Given this list of marker genes WDR20, PPP2R2D, WWP2, PIGB, TRIM24, SSBP2, PSMC4, IKZF3, MAP7, PAG1, ALG13, KHDRBS1, ZNF207, SPPL2A, FOXN3, TRGV3, SLC40A1, IREB2 (iron responsive element binding protein 2), TRIM33, TSPYL1, CLPX, PPT1, NUDT9, RBBP4, GPR160, CA2, CXCR6, SRP54, HNRNPF, RIPK2, ABLIM1, SWAP70, TSNAX, DPYD, RIN2, HSPH1, CD96, LIPA, CCDC50, PRDM8, ZNF23 (zinc finger protein 23, NCBI Gene Id 91855), MXI1, MLKL, SLC15A4 (solute carrier family 15 member 4), ZCCHC9, RAB5A, COPB1, MTR, TCHP, CDC14A, IDE, CCT4, ARID2, UBXN4, CD8A, NFE2L2, KLF4, ELOVL5, SYPL1, PROSER1, PGRMC2, THEMIS, GBP1, PACC1 (NCBI Gene Id 55248), INPP4A, MAX, ARF4, JMJD1C, NBPF11, ZNF274, DIMT1, AHCTF1, RUNDC1, FCRLA, LILRB2, HERPUD1, TARP, SERPINE2, TTYH2, PKIA, CRTAP, BANK1, LRRC37B, FAM117B, AGAP6, TPK1, MCL1, CDC5L, ANAPC16, SLC35E3, RELCH, ZNF700, KHDC4, ST6GAL1, ITM2B, PUM1, SEC24B, OSBPL10, OGFRL1, ALDH2, RAB1A, PTEN, HLA-DPB1, KPNB1, TSEN15 (NCBI Gene Id 92120), FAM149B1, PTGDR, LIPT1 (NCBI Gene Id 51601), TMEM69, TSC22D3, TRAK1, EVI2B, RSPH3, SMARCA5, MFSD6, MAF, MARCKS, USP24, LAMP2, USP48, MAN2B2, ZFP36L2, RSBN1L, GSPT2, TRAPPC11, SCAF8, LMBRD1, UBE2E3, MRI1, SCAF11, RBM12, PLEKHB2, MAU2, PTGER4 (NCBI Gene Id 5734), ANXA7, TIA1, ELMO2, SNAP23, JAK1, KYAT3, CDK2AP1, ZNF621 (NCBI Gene Id 285268), CPQ, SLC25A43, RCBTB2, FPR2, ZMIZ1, GMPS, ABHD5, UBTD2, PXYLP1, NRBF2, ALDH1A1, RBBP5, PPM1A, TRIM23, MFSD14B, EXOC1, NPTN, TRNAU1AP, MORC3, VKORC1L1, CIAO1, CTSC, FCRL3, SGK1, WAC, SH2B3, ZNF654, SDHD, STK26, UBE2G1, MPZL1, RBM47, AFF3, HSD17B11, TCP1, TGFBR2, BID, ZNF567, TRMT1L, ATOSA, ABITRAM, SRP14, MRPS30, NIP7, OSBPL9, ZNF407-AS1, JKAMP, NFAT5, TMEM192, RNF13, CHMP2B, ATMIN, ZFP3, DSE, TENT2, KCTD6 (NCBI Gene Id 200845), TOPBP1, CASP8, RESF1, TAF2, NCOA1, FAM120A, SP100, AXIN2, MPPE1, PPM1D, TLR6, IKZF5, PHOSPHO2, SOCS2, PRKCH, CDKN1B, ZNF586, ATG4C, HPRT1, TMEM248, CIPC, IFIH1, S100PBP (NCBI Gene Id 64766), SEC22C, CAMK2G, PRPS2, WIPF1, PIP4P2, CEP95, RBMS1, ZC3H14, ATP1B3, VPS35 (VPS35 retromer complex component), FBXO21, TLR2, FBXO7, MAT2B, NNT, PSIP1, RELL1, GGPS1, DEGS1, ETFRF1, YBX1P2, YIPF4, here is a description of the gene set: BACKGROUND: Neisseria meningitidis is a globally important cause of meningitis and septicaemia. Twelve capsular groups of meningococci are known, and quadrivalent vaccines against four of these (A, C, W and Y) are available as plain-polysaccharide and protein-polysaccharide conjugate vaccines. Here we apply contemporary methods to describe B-cell responses to meningococcal polysaccharide and conjugate vaccines. METHODS: Twenty adults were randomly assigned to receive either a meningococcal plain-polysaccharide or conjugate vaccine; one month later all received the conjugate vaccine. Blood samples were taken pre-vaccination and 7, 21 and 28 days after vaccination; B-cell responses were assessed by ELISpot, serum bactericidal assay, flow cytometry and gene expression microarray. RESULTS: Seven days after an initial dose of either vaccine, a gene expression signature characteristic of plasmablasts was detectable. The frequency of newly generated plasma cells (CXCR3<sup>+</sup>HLA-DR<sup>+</sup>) and the expression of transcripts derived from IGKC and IGHG2 correlated with immunogenicity. Notably, using an independent dataset, the expression of glucosamine (N-acetyl)-6-sulfatase was found to reproducibly correlate with the magnitude of immune response. Transcriptomic and flow cytometric data revealed depletion of switched memory B cells following plain-polysaccharide vaccine. CONCLUSIONS: These data describe distinct gene signatures associated with the production of high-avidity antibody and a plain-polysaccharide-specific signature, possibly linked to polysaccharide-induced hyporesponsiveness. species: Homo sapiens Genes down-regulated in peripheral blood mononuclear cell 7d after second dose vs 7d after first dose in adult (30-70) after exposure to Menveo/ACWYVax, time point 7D. Comment: second dose at 28 days from publication O'Connor D, Clutterbuck EA, Thompson AJ, Snape MD, Ramasamy MN, Kelly DF, Pollard AJ (PMID 28137280) Human Gene Set: OCONNOR_PBMC_MENVEO_ACWYVAX_AGE_30_70YO_7DY_AFTER_SECOND_DOSE_VS_7DY_AFTER_FIRST_DOSE_DN